Given this list of marker genes FKBP5, CREBL2, HSD3B1, DDX41, P4HA2, GRK5, ACP2, DUSP3, GK, PTP4A1, TLN1, COL15A1, PTPRN, BNIP3L, NLK, STIP1, FDXR (ferredoxin reductase), HSD11B1, JMJD6, PSMD1, MSMO1, MAP2K1, SGK1, GPRC5B (NCBI Gene Id 51704), PLPP1, PTPN21, ARHGEF5, CYP11A1, PSMC3, MAP1LC3B2, RAB1A, PHKA2, BECN1, NOL3, PRKAR1A, BAD, RHOB, CDC42EP4, CHUK, TMBIM6, TUBB2A, GNLY, RAB27A, CFLAR, PPFIA4, DUSP1, COL18A1 (collagen type XVIII alpha 1 chain), RAB2A, MAP3K7, EZR, ATP2A2, PGRMC1, ATP2B1, RAB4A, ADGRG1 (NCBI Gene Id 9624), UPP1, HSD3B2, PRKX, PDXK (NCBI Gene Id 8566), DUSP9, TNFAIP3, MAPK14, ARPC4, CDK16, POP5, DHCR7, CD55, GDE1, RAB14, GNAS, ATP5IF1, PGK1, SMARCA4, ARPC1A, PPP2R1A, ALPL, BAG1, MAP3K5, STAR, PPP2R5B, TFPI2, CYP19A1, MBD2, ITPR1, PLIN3, CASP9, ACP3, LHCGR, here is a description of the gene set: Human Gene Set: SASSON_RESPONSE_TO_FORSKOLIN_UP species: Homo sapiens from publication Sasson R, Rimon E, Dantes A, Cohen T, Shinder V, Land-Bracha A, Amsterdam A (PMID 15026540) Gonadotrophins exert a major effect on ovarian development and on the control of fertilization. By stimulating cells with forskolin (FK), it is possible to study which genes are activated by gonadotrophins via the cAMP cascade, and which by alternative pathways. Using RNA isolated from stimulated cells, we found that 59% of the total genes modulated by LH were also modulated by FK, while 69% of the genes modulated exclusively by FSH were also modulated by FK. Gene transcripts involved in steroidogenesis/progesterone production were highly elevated, while 17beta-hydroxysteroid dehydrogenase was down-regulated. This suggests that a decrease in the conversion of androstenedione to testosterone and estrone to estradiol occurs during luteinization. Down-regulation of genes coding for actin cytoskeleton proteins and cytokeratin 18 was observed in response to gonadotrophin and cAMP stimulation. Several of the genes coding for the microtubule network were also modulated, implying that rearrangement of the cytoskeletal proteins permits better coupling between organelles involved in steroidogenesis. A dramatic change in gene transcripts coding for signalling enzymes was observed following LH stimulation. This includes the down-regulation of adenylyl cyclase 7 and 9, elevation of cAMP-dependent phosphodiesterase, and the up-regulation of a negative regulator of G-protein signalling (RGS16) that may negate gonadotrophin signalling via guanine nucleotide binding proteins. Thus luteinized cells, despite increased gene transcripts to LH/chorionic gonadotrophin (CG) receptors, respond inefficiently to gonadotrophin stimulation, due to attenuation of signal transduction in the cAMP cascade at multiple steps. Novel genes involved in the regulation of apoptosis were found for the first time to be up-regulated by gonadotrophin stimulation, including: BAX inhibitor-1, granulysin and apoptosis repressor with caspase recruitment domain (ARC). These proteins may be involved in a unique alternative pathway of ovarian cell death. Such a pathway could temporarily preserve the mitochondria and progesterone production during the initial stages of granulosa cell apoptosis. Genes up-regulated in primary granulosa cells in response to forskolin.